The following is a description of a gene set: The transforming growth factor-beta (TGF-beta)-Smad signaling pathway inhibits the growth of human epithelial cells and plays a role in tumor suppression. The Smad4 gene is mutated or deleted in 50% of pancreatic cancers. In this study, we succeeded in establishing Smad4 knockdown (S4KD) pancreatic cancer cell lines using the stable RNA interference (RNAi) method. Smad4 protein expression was reduced dramatically and TGF-beta-Smad signaling was markedly inhibited in the S4KD cell lines. The S4KD and control cells were stimulated with TGF-beta and analysed using a cDNA microarray that contained genes, in order to screen for target molecules downstream of TGF-beta. The microarray analysis revealed that 187 S4KD genes and genes in the control cells were regulated immediately upon TGF-beta stimulation. Quantitative RT-PCR analysis on several of these genes produced results that corroborated the outcome of the microarray analysis. Most of the genes in the S4KD and control cells identified by the array differed, which suggests signaling pathways that differ according to Smad4 status. Of the identified genes, 246 have not been reported previously as genes that lie downstream of TGF-beta. Genes that are involved in cell proliferation, adhesion, and motility were found to be regulated differentially with respect to S4KD and control cells. Cell migration induced by TGF-beta was inhibited in the S4KD cells, which might be associated with a different regulation of integrin beta7. The knock down of a specific gene using stable RNAi appears to be a promising tool for analysing endogenous gene function. Genes up-regulated in PANC-1-S4KD cells (pancreatic cancer; SMAD4 knocked down by RNAi) after stimulation by TGF1B for 2 h. Human Gene Set: JAZAG_TGFB1_SIGNALING_VIA_SMAD4_UP species: Homo sapiens from publication Jazag A, Ijichi H, Kanai F, Imamura T, Guleng B, Ohta M, Imamura J, Tanaka Y, Tateishi K, Ikenoue T, Kawakami T, Arakawa Y, Miyagishi M, Taira K, Kawabe T, Omata M (PMID 15592526), and this is the list of marker genes: DNAH2, PTMA, MPDU1, ITIH3 (inter-alpha-trypsin inhibitor heavy chain 3), PTPRC, FKBP8, CBX5, ERCC5 (NCBI Gene Id 2073), HCN4, SRRM1, MRPS31, APH1A, FXR2, MRPL48, MYO1F, RFX4, ENO1, GPR45, POP7, ACTB, KRT38, PEG3, MRPL4, UBA2, TSPOAP1, MBD1, IFI35, COPZ1, PCGF2, HMGA1, TPPP3, MYL11, NPRL2, GABRB1, PGRMC2 (NCBI Gene Id 10424), STK25, HAS3, HEBP1, GATA4, RACK1, GRHPR, RAB4B, UBIAD1, PPP1R17, JPT1, HS3ST3A1, CGA, HGF, CRADD, C5AR1, SEM1, LSP1, SERTAD1, PDZK1IP1, MYO18A, NOSIP, C1QB (NCBI Gene Id 713), PILRA, CYP1B1, WIPI2, DAXX, COG2, IGF2BP1, GPR37L1, ARHGEF5, TP53, HDAC4, SATB1 (NCBI Gene Id 6304), CELF2, NOCT, RAMP1, CAMK2B (calcium/calmodulin dependent protein kinase II beta), CBX2, CNIH1, SRCAP, WDR45, PAX9, CELSR3, PADI3, FGF12, LBX1, EP300, TP53I11, CDIPT, LHX2, SPINK5, TOM1, CD27, GLRX2, CDH6, MYBL2, SLC23A1, CAB39, PKIG, OSGIN1, NAMPT, VCX, EIF1, KLK11, CDK20, OR10H2, TOM1L1, MUC6, CNPY3, YWHAE, NUP153, LPAR2